Given this list of marker genes EIF3D, RPL39L, EIF3A, EIF3G, EIF3K, RPL36AL, RPL36, RPS15A, RPS9 (NCBI Gene Id 6203), EIF2B1, RPS10, RPS28, RPS26, RPS2, RPL14, UBA52, RPL15, RPS21, RPSA, RPS4X, RPS14, 28S rRNA, RPL27A, RPL13A, RPL22, RPL19, RPL28, RPLP0, RPL7, RPL6 (ribosomal protein L6), RPL10, RPL24, RPL22L1, RPL32, RPS20, RPS17, RPL30, RPL23, RPS4Y2, EIF3F, EIF3H, EIF1AX, RPL26L1, EIF4B (NCBI Gene Id 55378), RPL36A, RPLP1, RPS23, EIF4G1, 5S rRNA, RPS16, RPL17, RPL11, EIF2B5, RPS7, 18S rRNA, RPS4Y1, RPL26, RPS5, EIF2S1, RPS6, EIF2B4, RPL35A, EIF4H, RPL7A, EIF4A2, RPS29, EIF2S2, EIF3E, RPL27, RPL10L (ribosomal protein L10 like), EIF5, RPS19, RPS3, FAU, RPS27A, EIF3I, RPL13, RPS15, EIF4EBP1, RPL34, PABPC1, RPL5, RPL18A, EIF5B, RPS12, RPL4, RPS24, RPL8, RPS27 (NCBI Gene Id 6232), RPL37, 5.8S rRNA, EIF2B2, RPS18, EIF3L, RPL21, RPL37A, RPL41, EIF4A1, RPL3L, RPS25, RPS3A, RPL29, RPL3, EIF3B, EIF3J (NCBI Gene Id 8669), RPL9, RPS11 (ribosomal protein S11), RPL23A, RPL12, EIF4E, RPL10A, EIF3C, RPS13, RPLP2, RPL31, RPS27L, RPL18, RPL39, RPL38, RPL35, EIF2B3, RPS8, EIF2S3, EIF3M, here is a description of the gene set: part of: Translation Reactome Pathway: Eukaryotic Translation Initiation Initiation of translation in the majority of eukaryotic cellular mRNAs depends on the 5'-cap (m7GpppN) and involves ribosomal scanning of the 5' untranslated region (5'-UTR) for an initiating AUG start codon. Therefore, this mechanism is often called cap-dependent translation initiation. Proximity to the cap, as well as the nucleotides surrounding an AUG codon, influence the efficiency of the start site recognition during the scanning process. However, if the recognition site is poor enough, scanning ribosomal subunits will ignore and skip potential starting AUGs, a phenomenon called leaky scanning. Leaky scanning allows a single mRNA to encode several proteins that differ in their amino-termini. Merrick (2010) provides an overview of this process and hghlights several features of it that remain incompletely understood.<p>Several eukaryotic cell and viral mRNAs initiate translation by an alternative mechanism that involves internal initiation rather than ribosomal scanning. These mRNAs contain complex nucleotide sequences, called internal ribosomal entry sites, where ribosomes bind in a cap-independent manner and start translation at the closest downstream AUG codon.<br> Initiation on several viral and cellular mRNAs is cap-independent and is mediated by binding of the ribosome to internal ribosome entry site (IRES) elements. These elements are often found in characteristically long structured regions on the 5'-UTR of an mRNA that may or may not have regulatory upstream open reading frames (uORFs). Both of these features on the 5'-end of the mRNA hinder ribosomal scanning, and thus promote a cap-independent translation initiation mechanism. IRESs act as specific translational enhancers that allow translation initiation to occur in response to specific stimuli and under the control of different trans-acting factors, as for example when cap-dependent protein synthesis is shut off during viral infection. Such regulatory elements have been identified in the mRNAs of growth factors, protooncogenes, angiogenesis factors, and apoptosis regulators, which are translated under a variety of stress conditions, including hypoxia, serum deprivation, irradiation and apoptosis. Thus, cap-independent translational control might have evolved to regulate cellular responses in acute but transient stress conditions that would otherwise lead to cell death, while the same mechanism is of major importance for viral mRNAs to bypass the shutting-off of host protein synthesis after infection. Encephalomyocarditis virus (EMCV) and hepatitis C virus exemplify two distinct mechanisms of IRES-mediated initiation. In contrast to cap-dependent initiation, the eIF4A and eIF4G subunits of eIF4F bind immediately upstream of the EMCV initiation codon and promote binding of a 43S complex. Accordingly, EMCV initiation does not involve scanning and does not require eIF1, eIF1A, and the eIF4E subunit of eIF4F. Nonetheless, initiation on some EMCV-like IRESs requires additional non-canonical initiation factors, which alter IRES conformation and promote binding of eIF4A/eIF4G. Initiation on the hepatitis C virus IRES is simpler: a 43S complex containing only eIF2 and eIF3 binds directly to the initiation codon as a result of specific interaction of the IRES and the 40S subunit. studied in species Homo sapiens